Given this list of marker genes GABRG3, DGLUCY, CCNG1, HPCAL1, RAP2A, C2orf80, CKAP2, MAPKAPK3, EI24, PTPN14, POLK, BTG2, PIDD1, LPIN1, TMEM19, PDK4, FOXO3, EPHX1, ZNF750, DDIT4L, ARAP2 (ArfGAP with RhoGAP domain, ankyrin repeat and PH domain 2), TBC1D8, CPT1C, CGREF1, GTSE1, GPR75, PIERCE1, TM7SF3, AEN, BBC3, VPS36, CEP170B, PLK2, PPM1D, FAS, SESN2 (NCBI Gene Id 83667), TNFRSF10B (TNF receptor superfamily member 10b), GNE, DDIAS, CDC42BPG, DCXR, AMPD2, ANO3, PHLDA3, SLC19A2, TP53INP1, TAP1, APAF1, BAIAP2, INKA2, ZBTB7B, ZNF365, RXYLT1, HMCN2, RNF169 (ring finger protein 169), NR1D1, PMAIP1, SEC14L5, SUSD6, TRAFD1, RHBDF2, DENND2C, PRRG4, ERCC5, STOX2, MAP3K20, EDA2R, BAX, GRHL3, MAB21L3, IGDCC4, ZMAT3, KANK3, USP32, CDKN1A, DCAF4, RAP2B, GGTA1, BLOC1S2, H2AJ, USP2, SLC66A3, here is a description of the gene set: Human Gene Set: QUINTENS_EMBRYONIC_BRAIN_RESPONSE_TO_IR The mammalian brain is especially sensitive to ionizing radiation during development, as shown by the increased occurrence of mental retardation and small head size in children who were in utero exposed to ionizing radiation after the atomic bombings of Hiroshima and Nagasaki. These effects of prenatal irradiation can be mimicked by irradiation of mouse embryos during the organogenesis period. In order to better understand the early effects of ionizing radiation on the embryonic brain and immature neurons, we performed a microarray analysis on brains from mice irradiated with different doses at E11 and E14, as well as primary cortical neuron cultures at 14 h in vitro. RNA was extracted at either 2 h (brains) or 6 h (neurons) post-irradiation. This gene set includes genes that were differentially expressed in at least two different conditions, to generate a bona fide list of early radiation-responsive genes in the embryonic mouse brain. studied in species Mus musculus Genes up-regulated in the mouse embryonic brain or immature neurons at 2 h or 6 h, respectively after exposure to 1 Gy dose of ionizing radiation. from publication Quintens R, Verreet T, Janssen A, Neefs M, Leysen L, Michaux A, Verslegers M, Samari N, Pani G, Verheyde J, Baatout S, Benotmane MA (PMID 25681390)